The following is a description of a gene set: Mouse Gene Set: BURTON_ADIPOGENESIS_9 During cellular differentiation and development, it is recognized that many complex molecular mechanisms as well as precise patterns of differentially expressed genes occur in directing precursor cells toward a given lineage. Using microarray-based technology, we examined gene expression across the course of 3T3-L1 adipocyte differentiation. Total cellular RNA was isolated at times 0, 2, 8, 16, 24, 48, and 96 h following treatment with either standard hormonal inducers of differentiation; insulin, dexamethasone, isobutylmethylxanthine (IDX), or IDX plus trichostatin A (TsA), a histone deacetylase inhibitor and potent adipogenic inhibitor. cRNA was synthesized from cellular RNA and hybridized to high density Affymetrix MG_U74Av2 microarray gene chips containing 12,488 cDNA/Expressed Sequence Tags (ESTs) probe sets. From the IDX-only treated cells, all probe sets that were either unchanged or differentially expressed less than 2-fold throughout differentiation with respect to time 0 preadipocytes were excluded from further analyses. This selection resulted in a net of 1686 transcripts, 859 were increased in expression, and 827 were decreased in expression at least 2-fold across differentiation. To focus in on genes that were more specific to differentiation, the same analysis was performed on IDX plus TsA-treated non-differentiating cells and all probe sets from the IDX-only group that exhibited similar expression profiles in the non-differentiating TsA-treated group were excluded leaving a total of 1016 transcripts that were regulated only under differentiating conditions. Six hundred and thirty-six of these transcripts were elevated at least 2-fold and 380 exhibited a decrease in expression relative to time 0 preadipocytes. This group of genes was further analyzed using hierarchical clustering and self-organizing maps and resulted in the identification of numerous genes not previously known to be regulated during adipocyte differentiation. Many of these genes may well represent novel adipogenic mediators and markers of adipogenesis. Strongly down-regulated at 8-96 h during differentiation of 3T3-L1 cells (fibroblast) into adipocytes. species: Mus musculus from publication Burton GR, Nagarajan R, Peterson CA, McGehee RE Jr (PMID 15033539), and this is the list of marker genes: Thbs2, Nme4, Glmp (glycosylated lysosomal membrane protein), Cyth3, Cdkn2b, F3, Vcam1, Ctnnd1, Dok1, Plk2, Gstt1, Ephx1, Ifi30, Acvr2a, Bcar1, Tspyl4, Ndrg4, Mfsd1, Exoc4, Pcgf5, Spp1, Cebpd, Csrp1, Kifap3, Lgals9, Slc8a1, Ccl9, Cited2, Plat, Cxcl12 (C-X-C motif chemokine ligand 12), Fos, Armcx2, Skap2, Ccn1, Rock2, Anxa11, Fads1, H2-T10, Jup, Maoa, Cdkn2a, Prkcd, Akap12, Ggta1, Klf4, Snx6, Tpm1, AU021092, Nedd9, Fermt2, Galk2 (NCBI Gene Id 98931), Sfrp2, Cnn3, Txndc16, Gpc4, Ptgs2, Dpp7, Cdk4, Ccl7, Stxbp3, Eif4b, Acot10, Gas2, Reck, Ddah2, Lats2, Asap1, Gem, Hspa1l, Spart, Ccl2, Phlda1, Dnm1, Pla2g4a, Grn, Id3, Tpd52l1, Cxcl1, Rasa4, Hebp1, Rassf5, Rnf13, Csf1, Sirt2, Gstm1, Fzd2 (NCBI Gene Id 57265), Maged2